The following is a description of a gene set: Human Gene Set: GOCC_PHAGOCYTIC_VESICLE_LUMEN studied in species Homo sapiens The volume enclosed by the membrane of a phagocytic vesicle., and this is the list of marker genes: MPO, HGS, PGLYRP1, LTF, GNLY